Given this list of marker genes PKP2, CACNA2D1, GJA5, JUP, SCN5A, DSP (NCBI Gene Id 202512), TBX5, CTNNA3 (NCBI Gene Id 50620), RANGRF, TNNI3K, KCNA5, DSC2, TRPM4, SCN10A, DSG2, here is a description of the gene set: The process that mediates interactions between a bundle of His cell and its surroundings that contributes to the process of the bundle of His cell communicating with a Purkinje myocyte in cardiac conduction. Encompasses interactions such as signaling or attachment between one cell and another cell, between a cell and an extracellular matrix, or between a cell and any other aspect of its environment. species: Homo sapiens Human Gene Set: GOBP_BUNDLE_OF_HIS_CELL_TO_PURKINJE_MYOCYTE_COMMUNICATION